Given this list of marker genes TRIM21, CTSV (cathepsin V), BIN1, ZPR1, GBP4, HSPBP1, RCN1, NDRG1, PKIB, ST3GAL6, FXYD5, THRA, ANKRD33B, MDN1, MAGED2, KRT86, SIAE, CSF2RB (NCBI Gene Id 3564), MAPK8IP3, DSG2, NPC1, TCN2, STAT4, MGST2, DNTT, CCND2, CUBN, SOCS2, SSBP4, ZG16, SEMA7A, HEXA, IFIT2, DBNDD2, GRB7, CCL5, ACTN1, BCL2, EMP1, LRFN4, AHNAK, CHRNB1, ZYX, ITM2C, CD9, ADGRG3, PPIC, THY1, ADA, GTF2H1, ENTREP3, DAB2IP, VPREB1, HEMGN, EMB, ELOVL6, ANKRD28, WLS, SQLE, FRMD6, TBXA2R, EFNB3 (ephrin B3), UGT1A10, PTPN22, SIPA1, ANXA2, KLF10, AKR1C4, TNFAIP6, LTB, ENG, GIMAP4, RUNX2, ANXA1, IGLL5, here is a description of the gene set: from publication Hoffmann R, Seidl T, Neeb M, Rolink A, Melchers F (PMID 11779835) Gene expression profiles of five consecutive stages of mouse B cell development were generated with high-density oligonucleotide arrays from as few as 2 x 10(4) ex vivo isolated and flow-cytometrically purified cells. Between 2.8% and 6.8% of all genes change on differentiation from one cellular stage to the next by at least twofold. The entire pathway involves differential expression of 10.7% of all genes. Previously known expression patterns of genes (like surrogate light chain, RAG-1/2, MHC class II, mel-14 antigen) are confirmed. The gene expression patterns of the proliferating pre-BI and large pre-BII cells on the one hand, and the resting immature and mature B cells on the other hand, are most similar to each other. Small pre-BII cells display a pattern that is transitional between these two groups. Most of the genes expressed in early precursors are involved in general processes, like protein folding or cell cycle regulation, whereas more mature precursors express genes involved in more specific molecular programs (cell surface receptors, secreted factors, and adhesion molecules, among others). Between 19 and genes share a given expression pattern. Combining knowledge about gene function and expression pattern allows identification of novel candidate genes potentially involved in self-maintenance of pre-BI cells, allelic exclusion and pre-B cell receptor signaling in large pre BII cells, cell-cycle arrest of small pre-BII cells, propensity toward apoptosis or anergization in immature B cells, propensity toward cell division and activation in mature B cells, and stage-specific interactions with stromal cells in the bone marrow. Human Gene Set: HOFFMANN_PRE_BI_TO_LARGE_PRE_BII_LYMPHOCYTE_DN studied in species Mus musculus Genes down-regulated during differentiation from pre-BI to large pre-BII lymphocyte.